Given this list of marker genes HLX, TNFSF4, MALT1, PRKCZ, RIPK2, IL18, CD86, ANXA1, IL4R, BRD4, IL23R, SHB, RARA, OPA1, CD80, IL23A, GPR65, NFKBID, CCL19, SOCS5, NFKBIZ, IL12RB1, BRD2, NLRP3, MIR21, IL12B, EP300, here is a description of the gene set: studied in species Homo sapiens Human Gene Set: GOBP_POSITIVE_REGULATION_OF_T_HELPER_CELL_DIFFERENTIATION Any process that activates or increases the frequency, rate or extent of T-helper cell differentiation.